Given this list of marker genes Ptgds, Grp, Ptafr, Syk, Vamp2, Snap23, Chga, Lyn, Ywhaz, Gab2, Pikfyve, Nr4a3 (nuclear receptor subfamily 4, group A, member 3, NCBI Gene Id 18124), Fcgr4, Nckap1l, Stxbp1, Mrgprb1, Il4ra, D6Wsu163e, Stx11 (NCBI Gene Id 74732, syntaxin 11), Itgb2, Rab27a (NCBI Gene Id 75673), Pram1, Mrgprx2, Ccl3, Spi1, Itgb2l, Gata1, Ms4a2, Lat, Slc18a2, Anxa3, Stx4a, Nppa, Adora2b (NCBI Gene Id 632506), Pla2g3, Snx4, Pld2, Tac4, Pi4k2a, Pdpk1, Cd160, Scn11a, Lypd10, Ighe, Crhr1, Lypd11, Lat2, Ap1g1, Bcr, Gata2, Hmox1, Kit, Il4, Nkg7 (NCBI Gene Id 72310), Cplx2, Nppc, Stxbp3, Gpr15lg, Fes, Fcer1g, Cd84, Cd177, Adora3, Foxf1, Clnk, Btk, Rac2, Myo1f, Fcer1a, Rabgef1, Lgals9, Kctd9, Ceacam1, Milr1, Il13, Abr, Coro1a, Il13ra2, Sphk2, Rasgrp1, Stxbp2, Cbl, Lamp1, F2rl1, Itgam, Unc13d, Cd300a, Fgr, Ptgdr, Rab44, Vamp8, Ccr2, here is a description of the gene set: species: Mus musculus Mouse Gene Set: GOBP_LEUKOCYTE_DEGRANULATION The regulated exocytosis of secretory granules by a leukocyte.